Given this list of marker genes H3-3B (NCBI Gene Id 3021), LUM, RPS8 (NCBI Gene Id 6202), N4BP2L2, S100A6 (NCBI Gene Id 6277), EGR1, CALD1, ST13, SELENOP, TOMM7, APOE, BEX3, C1R, IGFBP5, RPL11, SERPINF1, C1S, OGN, FOSB, HMGN2, RPL32, HES1, COL6A2, SERPING1, FOS, TCEAL4, JUN, ZFP36, TMEM258, SEPTIN7, RPL38, RPL17, RPL35A, HSPA1B, COL6A1, CYB5A, RPL37, IFITM3, BST2, RPS18, UQCRB, PDK4 (NCBI Gene Id 5166), RPS23, RPS15A, C12orf57, MFAP4, RARRES2, RPL39 (ribosomal protein L39), RPL21, DUSP1, RPL36 (NCBI Gene Id 92364), PFDN5, RPL26 (ribosomal protein L26), RPL36A, CIRBP, RPL7, CEBPD, TIMP2, SNHG32, GSTM3, COMMD6, RPS24, ID2 (inhibitor of DNA binding 2), ITM2B, ZFP36L1, JUNB, RPL41, LAPTM4A, TPM2, HMGN3, RPS27, TCEAL9, COX6C, RPS13, NBL1, SELENOM, COL1A2, COL1A1, PEBP1, C7, SNRPD2, RPS15, LGALS1, RPL24, NBEAL1 (NCBI Gene Id 653928), TMA7, RPL23A, RPS20, OST4, RPLP1, RPL31 (NCBI Gene Id 6160), RPL30, DCN, DDIT4, RPL34, MDK, RPL12, NUCKS1, here is a description of the gene set: Human Gene Set: FAN_OVARY_CL2_PUTATIVE_EARLY_ATRETIC_FOLLICLE_THECAL_CELL_1 from publication Fan X, Bialecka M, Moustakas I, Lam E, Torrens-Juaneda V, Borggreven NV, Trouw L, Louwe LA, Pilgram GSK, Mei H, van der Westerlaken L, Chuva de Sousa Lopes SM (PMID 31320652) studied in species Homo sapiens TC from (early atretic) follicle D and present in stromal samples were mainly present in CL2 and CL6 (Fig. 4a, Supplementary Fig. 2c), suggesting that those may represent atretic TC. The TC in CL2 and CL6 expressed IFITM3, lower levels of COL3A1 and higher levels of FOS and IGFBP5 compared to the TC in CL5 (Fig. 8a).